Given this list of marker genes Cav1 (caveolin 1, caveolae protein), Capn1, Bsx (brain specific homeobox), Nfkb1, Elf3, Cdkn2a, Bax, Pml, Stat5a, Igfbp5, Vdr, Ccl2, here is a description of the gene set: species: Mus musculus The tissue remodeling that removes differentiated mammary epithelia during weaning. Mouse Gene Set: GOBP_MAMMARY_GLAND_INVOLUTION